Given this list of marker genes CXCL12, CXCR2, TGFB3, ADM, ENG, ANG, EFNA1, FGF2, VEGFA, TGFA, NOS2, PDGFA, here is a description of the gene set: from publication Mizukami Y, Jo WS, Duerr EM, Gala M, Li J, Zhang X, Zimmer MA, Iliopoulos O, Zukerberg LR, Kohgo Y, Lynch MP, Rueda BR, Chung DC (PMID 16127434) Genes up-regulated in DLD-1 cells (colon cancer) in response to hypoxia; might not be direct targets of HIF1A. studied in species Homo sapiens Human Gene Set: MIZUKAMI_HYPOXIA_UP Hypoxia inducible factor-1 (HIF-1) is considered a crucial mediator of the cellular response to hypoxia through its regulation of genes that control angiogenesis. It represents an attractive therapeutic target in colon cancer, one of the few tumor types that shows a clinical response to antiangiogenic therapy. But it is unclear whether inhibition of HIF-1 alone is sufficient to block tumor angiogenesis. In HIF-1alpha knockdown DLD-1 colon cancer cells (DLD-1(HIF-kd)), the hypoxic induction of vascular endothelial growth factor (VEGF) was only partially blocked. Xenografts remained highly vascularized with microvessel densities identical to DLD-1 tumors that had wild-type HIF-1alpha (DLD-1(HIF-wt)). In addition to the preserved expression of VEGF, the proangiogenic cytokine interleukin (IL)-8 was induced by hypoxia in DLD-1(HIF-kd) but not DLD-1(HIF-wt) cells. This induction was mediated by the production of hydrogen peroxide and subsequent activation of NF-kappaB. Furthermore, the KRAS oncogene, which is commonly mutated in colon cancer, enhanced the hypoxic induction of IL-8. A neutralizing antibody to IL-8 substantially inhibited angiogenesis and tumor growth in DLD-1(HIF-kd) but not DLD-1(HIF-wt) xenografts, verifying the functional significance of this IL-8 response. Thus, compensatory pathways can be activated to preserve the tumor angiogenic response, and strategies that inhibit HIF-1alpha may be most effective when IL-8 is simultaneously targeted.